Given this list of marker genes Klf13, Map3k9 (NCBI Gene Id 338372), Nhsl3, Myorg, Tdrd1, Rap2a, Atp11a, H13 (histocompatibility 13), Pafah1b1, Trim26, Msantd5f10, Nipa2, Gpcpd1, Reep3, Gucy2f, Ikbkg, Cbln1, Rbbp4, Polr3b, Hnrnpk, Gm2042, Kcnj6, Veph1, N4bp1, Sgcd, Lrtm2, Vwc2l, Ppm1f, Cobl, Csmd1, Rab3gap1, Cops8, Myot, Pip4k2a, Mtbp, Kctd21, Tmem132b (transmembrane protein 132B), Fmn2, Lrrc28, Dazap2, Nr6a1, Prlr, Slc35d1, Mmp16, Kif5b, Iffo2, Nfix, Ntpcr, Rala, Msantd5f2, Or10d5j, Actc1, Krtap5-4, Ago2, Rdh1, Med13, Msantd5f7, Ergic1, Pramel51, Enoph1, Sox14, Pou2f2, Ark2c, Chic1, Irgm1, Wnt9a, Onecut2, Fstl5, Lrit1, Lrp11, Col6a6, Osbpl3, Msantd5f3, Pom121, Mrm1, Ralgapb, Slc28a1, Wnt1, Twist1, Fat1, Hmgxb4, Dnajb2, Natd1, Tafa1, Plod1, Hdac1, Tsc22d2, Ehhadh, Dagla, Kif3b, Gm38423, Nedd4l, Tmem151a, Sh3pxd2b, Nectin3, Nipal1, Tarbp2, Man1c1, Rfx3, Msantd5f8, Filip1, Mmp24, Ppfia2, Csf2rb, Reep1, Arl8b, Clmn, Col6a3, Msantd5f4, Aff4, Amz1, Ptgfrn, Hap1, Six6, Kcnh1, Nfatc2, Slc20a1, Msantd5f5, Gbp2b, Slc25a32, Taok1 (NCBI Gene Id 67240), Ctbp2, Tmod3, Gldn (NCBI Gene Id 235379), Zfp74, Oog1, Mid1, Efr3b, Fmr1, Pvr, Oxct1, Efna5, Pdgfra, Ankrd24, Slc39a2, Msantd5f1, Kcnd3, AW554918, Zfhx4, Pbx3, Dio2, Tbcb, Atrn (NCBI Gene Id 99420), Rdh16f2, Pde2a, Camkk1, 4933427D14Rik, Tasl, Ubxn7, Vdr, Polr3e, Ifnar1, Lig3, Fbxl20, Rcsd1, Il1a, Ulk3, Rtf1, Zbtb33, Slc25a25, Syngr3, Zfp329, Clrn3, Agbl4, here is a description of the gene set: Genes predicted to be targets of miRBase v22 microRNA mmu_miR_5113 in miRDB v6.0 with MirTarget v4 prediction scores > 80 (high confidence targets). from publication Chen Y, Wang X (PMID 31504780) Mouse Gene Set: MIR_5113 studied in species Mus musculus